The following is a description of a gene set: from publication Yevshin I, Sharipov R, Kolmykov S, Kondrakhin Y, Kolpakov F (PMID 30445619) Human Gene Set: INSM2_TARGET_GENES Genes containing one or more binding sites for (INSM2) in their promoter regions (TSS -1000,+100 bp) as identified by GTRD version 20.06 ChIP-seq harmonization. species: Homo sapiens, and this is the list of marker genes: NOL8 (nucleolar protein 8), RNU6-1039P, XPO6, TRIP4, PLEKHG7, SLC15A1, CKB, NR4A3, RFTN1 (raftlin, lipid raft linker 1), CENPK, SMARCD2, H4C4, EML2, RAD51AP1, GINS1, RING1, MCOLN1, GCHFR, DYNLT2B, OGT, NUBPL-DT, RPS7, PNO1, SNAP47, VIM, FAF2, MRPS31, KCTD21, LYPLA2, CENPP, KCNQ2, RBFOX2, TRAM1, LBX1-AS1, GFM2, PGS1, KLRK1 (NCBI Gene Id 22914), SOWAHC, SNX10-AS1, AMPD3, SUPT7L, LINC02960, NBPF19, ZBED6, TEAD1, CREB5, GZF1, MED26, PYGB, ARHGEF10, APPBP2 (NCBI Gene Id 10513), ZC3H11A, POLE4, RNU6-821P, MAFK, PCNT, MRPL45P2, GARS1-DT, DNAAF10, MYL12-AS1, KAT6A, TLCD3B, VXN, ADAR, GTF2I, WARS1, JMJD4, NAGPA, SPOP, CDKN2AIPNL, HSPD1, SLC25A53, ZNF165, ERBB3, RNF150, MRPS31P4, SKIDA1 (SKI/DACH domain containing 1), CEP95, RNF220, HCG27, SOX8, CHEK1, RPS3A, NAV2, PDE12, LINC02172, ZNF433, DMAP1, ZNF790-AS1, NOC4L, BRMS1L, TMEM260, RAD21L1, GNAL, EMC3, RAD18, MTFR2P2, YJU2, ARHGAP21, RNF215, JPX, DYNLT2, ZNF260 (zinc finger protein 260), TMEM259, MRPL45, DSTYK, ZCCHC24, RPL36AP8, CFAP61, PRC1, RANBP1, RN7SL446P, HIVEP3, CEROX1, IQCH, CLIP1, POU3F1, AP3S2, MIR4727, CCNG2, PCSK2, PPP2R5C, COTL1, SRFBP1, PIPOX (NCBI Gene Id 51268), LMNB1-DT, C6orf226, PTPN14, NUP214, STX16-NPEPL1, HOXC5, KTN1, C9orf43, STX3, ALDOA, SMAD1, MEGF10, PKM, UBXN6, CWC25, DZIP1L, DDX41, TEAD4, ELFN2, SH3PXD2B, HTD2, CSNK1G3, NDUFC2, REV1, PDE8A, CCDC77, RNVU1-14, DUS1L, ZMPSTE24-DT, ALG1 (ALG1 chitobiosyldiphosphodolichol beta-mannosyltransferase), SCRIB, HMGA2, SPAG9, HOXB-AS3, PURB, ALKBH3, LINC02831, PHF20, TBL1X, NUCKS1, MARCHF8, SMG7-AS1, TM7SF3, RN7SL2, MVK, KAZN, NDUFB6, HOXB3, GOLGA3, ACTBL2, GUSBP11, KLC1, SEMA6A, C10orf88, SLC44A1, XKR8, CASZ1, ENC1, CCDC97, PHRF1 (PHD and ring finger domains 1), SNTA1, XPC-AS1, GPR107, PRICKLE2-AS3, LMF1 (NCBI Gene Id 650392), KHDRBS1, TSC1, GARS1, SYTL2, HMGB2, KLHDC8A, GNB2, AXL, SCUBE1-AS1, BHLHE40, TMEM121B, KRT18, STX18, RNU6-2, SLC16A6, DOCK7, PTPRM, ISG20, RGS5, SH3D21, INO80B, HMBS, CLN3, NUAK1, TAF15, NR2F1-AS1, EIF2D, POP4, OSBP, LACTB2-AS1, DPP9, SGSM2, MIR194-1, NUDT18, IGF1R (insulin like growth factor 1 receptor), KLHL32, ASCC1, ATAD3A, STARD10, NFIB, IRS2, PRKG1, MRPL4, LINC00649, DRAIC, TFRC, YARS1, PRSS23, TSKU, LINC00680, RAPGEF5, UBE2I, LIG1, PLEKHG5, GANC, TK1, AMOTL2, TBC1D9, THG1L, STRN3, PDE4A, CCT2, UCHL5, PRKCI, GPR85, RRAS2, B4GAT1-DT, RNU5D-1, VPS51, WDR25, AKIRIN2, ENAH, CFAP276, LEISA1, LIMA1, EZH2, PPP5D1P, DDX5, HEXA-AS1, SEC22B, CTSA, HOXA-AS2, CAPZA2, NR2C1, WWC2 (WW and C2 domain containing 2), PIAS1, FOXJ3, PPP3R1, ITM2C, MAP3K13, CBX4, FANCC, ENSG00000261840, ADPGK, CLCN6, ODR4, EHHADH, ACOT7, GTF2IP12, HBP1, KIAA0319L, FZD1, SMAP2, SALL2, FOXB1, ENTPD6 (ectonucleoside triphosphate diphosphohydrolase 6), MIR1273C, GFI1B, ING4, INHA, VPS29, CAPS2, AP4M1, HEXA (NCBI Gene Id 3073), TBL3, WDR11, PPM1A (protein phosphatase, Mg2+/Mn2+ dependent 1A), SLMAP, USPL1, KRT19, STX18-AS1, ALOXE3, CPEB2-DT, DHRS7B, NEMP1, RHOBTB3, GABPB2, FOXN3-AS1, FRMD4B, PFKFB3-AS1, MYL6B-AS1, ARPP19, KDM3A, DUSP6, ZNF408, LINC02609, LINC01778, LGALS8, LINC01003, KPNB1-DT, SKIL, VARS2, MAN2A2, RAB5IF, MYO5C, LMF2 (lipase maturation factor 2), APTX, PAFAH2, WDR37, STK40, FANK1-AS1, SNHG11, PITPNM2 (phosphatidylinositol transfer protein membrane associated 2), TGFB3, LINC02093, CFAP74, DHPS, SEC1P, ARVCF, ENSG00000246465, ZFX-AS1, TRMT2A, TSKU-AS1, RN7SL521P, ENSG00000247416, KRT8, ENSG00000232995, B4GAT1, TMEM141, SH2D5, SLC41A1 (solute carrier family 41 member 1), SEPTIN9, KDM1A, LAMP1, DOCK7-DT, NUDCD3, CSNK1D, TEFM, REXO4, ARRB1, YWHAZ, ZNF271P, TPR (NCBI Gene Id 7175), PIGL, LRP6, RARA, LINC01664, DBP, TFAP4, C17orf58, MYL12A, WSB2, SUDS3 (NCBI Gene Id 64426), ARMH3, PAPLN, ZNF674-AS1, DYNC1LI1, ENSG00000253270, PET117, NSA2, TMED1, DVL2, OSBPL8, RAI14, FLJ46284, NADK2, RAB2B, AFMID, C19orf38, LGALS8-AS1, STAT3, SH3BGRL3, INO80B-WBP1, CDC42EP4, RAD9B (RAD9 checkpoint clamp component B), TMTC2, VLDLR-AS1, ARHGAP24, KAT14, TMEM167B, WTIP, SLC25A23, POLE, SCAT2, DOHH, KDM7A-DT, ELF1, FEM1B, KLHDC9, ADGRL2, ITGA7, TMEM19, RHOBTB2, MAFF, ZNF169, TTC21B, YAP1, LMNB1, PTCH1, TOP3B, LATS2, ZBTB40, OBSL1 (NCBI Gene Id 731094), TCF3, RILPL1 (NCBI Gene Id 353116), MEGF6, FLT3, CASC3, B4GALT6, TRAJ7, TMEM248, H4C3, TM4SF19-AS1, BMS1, SREBF2, ECH1, PRRC2A, STAT6, LINC01547, ZNF398, LCN15, GARNL3, NDUFS7, AHI1-DT (AHI1 divergent transcript), SCAND3, MDM2, IRF9, HMGB1, TMEM167B-DT, TXNRD2, MAN1C1, TOR1A, ACOT9, PAK1, R3HDM2-DT, LSG1, NME1, SNORA13, CCDC192, DCAF8-DT, SNHG3, ZCCHC4 (zinc finger CCHC-type containing 4), PHF3, GIPC1, LINC01635, BCL7A, PACSIN2, MBTPS2, USP30, GPHN, PLAG1, NKAPD1, TNPO2, MYO3A, BCAN-AS2, ANAPC5, PITX2, PPCDC (phosphopantothenoylcysteine decarboxylase), EFCAB7, CREM, NCDN, RCC1, PALMD, CLCN7, RPL27, SNAP23, STX16, METTL9, ITFG2-AS1, TMEM87A, ZNF217 (zinc finger protein 217), GTPBP3, GATC, PITX1, ASXL1, IFTAP, LY6K, ARHGEF2, MALAT1, AHI1, OTULIN-DT, ZNF205, FANCD2, GTF2H4, DXO, EPB41L4A-AS1 (NCBI Gene Id 114915), UBC, SLC11A2, ARG2, RAB11B-AS1, PAWR, DAZAP1 (DAZ associated protein 1), LIAT1, TSR1, HOXC10, NEAT1, MTF2, SNHG17, SURF6, VTRNA1-2, SPNS1, MRPL1, TSC22D4, CFDP1, ZFP30, ZNF425, PEAK1, GSTCD, GBE1, SF3A3, NRP1, POLR2M, RO60, KCTD5, REPS1, NOP16, CCDC18-AS1, FANK1, BAX, SLC4A1AP, TADA1, NXN, CTNNB1, GBA1, MRPL27, CASTOR3P, MICOS10, PPP2R3B, NME1-NME2, PIM1, ILF3, TUT1, IPO4, TIMM22, KLKP1, MCC, FAM86FP, NDUFB7 (NADH:ubiquinone oxidoreductase subunit B7), ZNF555, KCTD9, ZKSCAN3, DRG2, HSPE1, TCF19, WWTR1, MTRFR, GTF3C5, CDK5RAP1, ZNF461, MCM7, WDR41, MIR3659HG, METTL15, LINC01411, ZC3H6, POLE3, NAB2, TRIAP1, CHEK2, BLOC1S1, TPI1P2, MDH1, ATG101, ABR, CCAR2, SPHK2, TSC22D1, ARHGEF1, AAGAB, BRPF1, ZNF213-AS1, ICMT-DT, CCDC159, ZNF593, PAWRP1, RASA4CP, CACUL1 (NCBI Gene Id 143384), SMARCA2, TRIB1, ANK1, FOS, FERRY3, MARCOL, SEPTIN7P1, DDX51, GTF2B, DISC1, HOXB9, TRIP6, FRAS1, USP35, MIR4530, C17orf75 (chromosome 17 open reading frame 75), STAU2-AS1, RAD23A, ZNF641, CACYBP, ITGB3BP, MYH9 (NCBI Gene Id 65212), MUC1, EIF6, UBA1, KLHL22, HNRNPA0, RAB11B, GUSBP1 (NCBI Gene Id 728411), LINC01132, ZBTB45, CDCA2, KRBA1, TLE3, THSD4, LINC01556, ZNF140, NR2F1, PICALM, EME1, MAP2K5, SAR1B, PGK1, IDI1, BASP1, ENPP3 (ectonucleotide pyrophosphatase/phosphodiesterase 3), LNC-LBCS, MIR3913-1, PCLAF, TBPL1, DCTPP1 (NCBI Gene Id 79077), MIOS-DT, H3-3B, CIDECP1, LINC02709, USP9X, HMG20A, STK19, ADRM1, ANKRD13A, RERE, TIPRL, SPRED2, NUS1, RBM17, FILIP1, ELAVL2, ENSG00000282849, RPS26, COPS7A, CDIP1, ZNF470-DT, RGS20, MLLT3, ZSWIM9, PDS5A, TSHZ2, ZNF470, HSPE1-MOB4, TRDMT1, ETHE1, MMAB, DAGLB, NUBPL, RCAN1, ELP3, MIR4999, RPA2, PBX2, SPEN, PTPN13, EXOSC3, AGTPBP1, MTFR2, CMTR1, MIR5700, DTD1 (NCBI Gene Id 92675), TM9SF4 (NCBI Gene Id 9777), IER3, RBBP7, PRKAG2, DCDC2B, HOXC-AS3, RFC1, KBTBD4, CREB3L2-AS1, INTS12, SMIM2-AS1, ZMPSTE24 (zinc metallopeptidase STE24), NUP155, METAP2, APOLD1, MPHOSPH9, COP1, CSDE1, LURAP1L-AS1, CLPB, SFR1, ITPR1, THBS3-AS1, JMJD1C, MIR1302-3, TOM1, EPHB1, PDXK, DNTTIP2, LINC00431, CHCHD7, PXMP2, S100A2, PPP1R37, BACH1, TSFM, ILF3-DT, EIF3F, MIR548AW, BASP1-AS1, DR1, HEXIM1, DNAJB12, CALM3, HNRNPA1, SLX9, NAGLU, LINC01775, LIN54, CGA, BACH2, PEPD, ZNF839, ACVR1B, MAGOHB, EVI5L, ABCB9, ANKRD10, NDUFS3, OTULIN, SMC3, FRA10AC1 (FRA10A associated CGG repeat 1), MRPL39, GCAT, ARHGAP1, SEPTIN7P14, SEPTIN7P13, RNVU1-31, SLC39A3, SELENOH, NMNAT1, SEMA7A, PTP4A2, KIAA0319, MYL6, PTPA, SDR39U1, DNAJC6, SBK1, HOXD11, MICOS10-NBL1, WDR24, LINC01275, ALKBH3-AS1, FCHSD2, PHIP, ELAPOR1, RPL18, MIR615, EP300, R3HDM2, PFKFB3, WDPCP, LZIC, KCNJ5, COX16, NEURL2, ISCA1, C12orf76, STX4, CCBE1, PRKCE, RCAN2, BCO2, MYPN, MEF2A, TLE4, LINC01010, NUBP1, SRCAP (Snf2 related CREBBP activator protein), LGI4, PKNOX1, COMMD4, TNFRSF10B, HOMER1, LINC00938, CABIN1, PIH1D2 (PIH1 domain containing 2), GPAM, WDR11-DT, MSRB3, NELFA, FNTB, NDUFC2-KCTD14, PHF1, BRWD1, C21orf58, ARID1A, PIK3R3, LRRC8A, CEBPG, RNU6-859P, ELAVL1, RPS18, PPIP5K2, KLHDC10, CDC7, NCAPH2, FNDC3B, GTF2IP20, TNPO3, CALM2, TARS2, NUF2 (NCBI Gene Id 83540), GLA, ENSG00000224865, MAPK4, FHL1, NFE2L2, EPHA2, BMF, GLRX3, SLC35E2B, NME5, ATF4, EEFSEC, APPBP2-DT, LYSET, EXD1, SSBP2, EMC3-AS1, SLC35E2A, SEC13, MYL12B, USP31, ACAT2, TOX4, GTF2A1-AS1, CAMK2N1, ZSCAN30, SEPTIN10, SLC33A1, SPAG4, H4C8, SAMD4A, PHF12, H4C1, ANKRD18B, ICMT, CCN2, AVPI1, MRPS31P5, LINC02599, CHP1, GLI3, JAGN1, VPS52, CDK12, S100PBP, RNVU1-23, LTBP1 (NCBI Gene Id 4052), TLE6, CENPC, CMTM3, TCEANC, FBXO27, HOOK1, NCAM1, VWA8, MECOM, CENPU (centromere protein U), KDM5A, H4C2, TOB2, NPAS3, MTHFR, ZMIZ1, SMG7, GTF2A1, ATAD2, MED23, MAX, CDC42SE1 (CDC42 small effector 1), NICN1, ERMARD, UNC5B-AS1, HDAC7, GPN3, RDUR, DCP1A, HNRNPH2, KRT75, FEM1A, EIF2B3, ENSG00000254718, PSTK, PLEKHM1, CT62, ANO8, RFFL, GIN1, CCN1, CCHCR1, ZNF433-AS1, ISLR2, RPP14, YTHDC1, DLEU1, ZNF674 (zinc finger protein 674), ARAP1, MIR5188, ARHGAP28, PARN, FLVCR2, LINC01592, GBA1LP, MEF2C, KPNB1, MAZ, ALDH1A2, AURKAIP1 (NCBI Gene Id 54998), EIF5, FAM216A, ADAP2, SETD1A, KDM7A, ZNF609, ASH1L, TRMT1, ETV5, EP400P1, LINC00957, SMG1P3, SMIM26, AP2M1, HIF1AN, ARAF, AARSD1, NCOR2, ZNF106, RCOR1, RHOQ, ENSG00000241525, LINC01145, TYSND1